The following is a description of a gene set: Genes negatively differentially expressed in cell type: CD4+ T cell upon treatment with cytokine: IL-13 in mouse lymph nodes in vivo. Mouse Gene Set: CUI_T_CELL_CD4_IL13_RESPONSE_DN from publication Cui A, Huang T, Li S, Ma A, Pérez JL, Sander C, Keskin DB, Wu CJ, Fraenkel E, Hacohen N (PMID 38057668) studied in species Mus musculus Cytokines mediate cell-cell communication in the immune system and represent important therapeutic targets. A myriad of studies have highlighted their central role in immune function, yet we lack a global view of the cellular responses of each immune cell type to each cytokine. To address this gap, the authors created the Immune Dictionary, a compendium of single-cell transcriptomic profiles of more than 17 immune cell types in response to each of 86 cytokines (>1,400 cytokine-cell type combinations) in mouse lymph nodes in vivo. A cytokine-centric view of the dictionary revealed that most cytokines induce highly cell-type-specific responses. For example, the inflammatory cytokine interleukin-1β induces distinct gene programmes in almost every cell type. A cell-type-centric view of the dictionary identified more than 66 cytokine-driven cellular polarization states across immune cell types, including previously uncharacterized states such as an interleukin-18-induced polyfunctional natural killer cell state., and this is the list of marker genes: Junb, Tsc22d3, Klf6, Jun, Hspa8, Hspa1a, Fos, Dnajb1, Uba52, Dnaja1, Hspa1b, Btg2